Given this list of marker genes D2HGDH, L2HGDH, IDH2, COQ4, IDH1, SLC25A1, here is a description of the gene set: Human Gene Set: HP_2_HYDROXYGLUTARATE_ACIDURIA 2-hydroxyglutarate aciduria The concentration of 2-hydroxyglutaric acid in the urine, normalized for urine concentration, is above the upper limit of normal. species: Homo sapiens